The following is a description of a gene set: Human Gene Set: GOBP_VACUOLAR_TRANSPORT species: Homo sapiens The directed movement of substances into, out of or within a vacuole., and this is the list of marker genes: NPC1, SNX16, CHMP6, VTA1, RAB7B, VPS37A, LRP1, HOOK3, LAMP2, ALS2, VPS33A, RHOB, HGS, C9orf72, VPS28, SNF8, MGRN1, ARL8B, VPS11, VPS37C, VPS41, SQSTM1, TMEM106B, TPCN2, VAMP7, AKTIP, CCDC91 (NCBI Gene Id 55297), VPS51 (NCBI Gene Id 739), NAGPA (N-acetylglucosamine-1-phosphodiester alpha-N-acetylglucosaminidase), LEPROT, WASH3P, CLN3, ADRB2, CHMP2B, MON1A, VPS39, STAM2, SLC30A3, MVB12A, VPS33B, DTX3L, PTPN23, PLEKHF1, AP4M1, HMGXB4, AP3B1, TMEM50A, PLEKHM1, PLEKHF2, HGSNAT, IGF2R, CHMP4B, VPS18, BECN1, MTM1, VPS36, MFSD1, NCOA4, GRN, STAM, UBAP1, AP3S2, RAB7A, CDX2, VPS13A, MVB12B, NEDD4, SCYL2, VPS37D, VPS53, VPS13D, HSPA8, ATP13A2, CHMP4BP1, LYSET, CLU, RBSN, VPS13C, EHD3 (NCBI Gene Id 30845), M6PR, SORT1, NDFIP1, VTI1A, HOOK2, SLC30A2, AP3D1, TSG101, NDFIP2, UBXN6, HSPA1A, USE1, VTI1B, VPS52, CHMP4A (charged multivesicular body protein 4A), LEPROTL1, AP1G2, ATP6V0D2, BECN2, LAPTM5, CHMP3 (charged multivesicular body protein 3), VPS54, LIPA, TMEM50B (NCBI Gene Id 757), ATP6V0D1 (ATPase H+ transporting V0 subunit d1), CHMP1B, GNPTG, CHMP1A, VIPAS39, AP1G1, NDP, UEVLD, ZFYVE16, AP3S1, VPS4B, PINK1, EPG5, MON1B, SORL1, PIK3C3, BIN1, TRAK1, GCC2, PRKN, VCP, HOOK1 (hook microtubule tethering protein 1, NCBI Gene Id 51361), SLC17A9, CHMP2A, VPS8, FHIP1B, RUFY4, GPRASP1, PCDHGA3, TRAK2, VPS25, VPS16, GGA3, VPS37B, PCSK9, LAMP1, VPS35, SLC30A4, CHMP4C, SNAPIN, VPS4A, ARSB, RAB12, PIK3R4, CHMP5, KIF13A, SCARB2, SNX27, CLEC16A, CHMP7, PSAP, LRRK2, SMURF1, DENND3, LYST, TGFBRAP1, ANKFY1, SLC48A1, SPTBN5, AP3M1, GNPTAB, ATG14, GAK, IRGM, RILP